The following is a description of a gene set: species: Homo sapiens Reactome Pathway: Defective RHAG causes regulator type Rh-null hemolytic anemia (RHN) part of: SLC transporter disorders Rhesus (Rh) blood group antigens consist of several membrane-associated polypeptides including RHAG, which is required for cell-surface expression of the complex. The Rh(null) phenotype arises from missing or severely deficient Rh antigens and sufferers present a clinical syndrome of varying severity characterised by abnormalities of red cell shape, cation transport and membrane phospholipid organisation. The human gene RHAG encodes a Rhesus blood group family type A glycoprotein (belonging to the SLC42 solute transporter family) which is expressed specifically in erythroid cells. A transport function for RHAG is suggested to mediate ammonium (NH4+) export from these cells and prevent toxic build-up of NH3/NH4+. Defects in RHAG are the cause of regulator type Rh-null hemolytic anemia (RHN, Rh-deficiency syndrome). RHN is a form of chronic hemolytic anemia (Huang & Ye 2010)., and this is the list of marker genes: RHAG (Rh associated glycoprotein)